Given this list of marker genes Cd44, Pdpn, Arhgap24, Plet1, Phldb2, Rhoc, Flna, Fermt2, Ceacam1, Rreb1, Itgav, Acvrl1, Hbegf, Pard3, Ajuba, Clasp1, Fermt1, Megf8, Ccn1, Mrtfa, Itga5, Scnn1b, Scnn1g, Cd151, Ddr1, Mtor, Lrg1, Rhoa, Pdcd10, Snai2, Carmil2, Mmp12, Arhgap35, Tmeff2, Clasp2, Msx2, Col5a1, Tor1a, Wnt7a, Pten, Itgb5, here is a description of the gene set: The expansion of one cell sheet over other cells or yolk. studied in species Mus musculus Mouse Gene Set: GOBP_EPIBOLY